Given this list of marker genes MLLT3, APC, MCCC2, ZFAND6, RNA5SP195, KLF5, PPWD1, GCNT3, SNORA73B, PPP1R12B, PDE4D, REXO2, VPS50, RBM33-DT, DTWD1, HMGN2P46, DNAJC21, FAM151B-DT, NR5A2, DUT, CLOCK, SLC41A2, MEF2C, TPM1-AS, HIKESHI, NEDD4, LSM5, CENPF, NXPE1, SNORD45B, MALAT1, LMO7, ARHGEF38, here is a description of the gene set: Human Gene Set: ALX4_TARGET_GENES studied in species Homo sapiens Genes containing one or more binding sites for (ALX4) in their promoter regions (TSS -1000,+100 bp) as identified by GTRD version 20.06 ChIP-seq harmonization. from publication Yevshin I, Sharipov R, Kolmykov S, Kondrakhin Y, Kolpakov F (PMID 30445619)